Given this list of marker genes NTHL1, RNASE2, RNASE3, OGG1, RNASEH1, DNASE1L3, RNASE4, PPP1R8, RNASE1, DNASE1L1, RNASE6, DNASE1, FEN1, RNASEH2A, here is a description of the gene set: Human Gene Set: MODULE_360 studied in species Homo sapiens Genes in the cancer module 360.